The following is a description of a gene set: species: Homo sapiens Activation of innate immune receptors including Toll-like receptors (TLRs) by pathogen-associated molecular patterns (PAMPs) is crucial in the host defense against microbial infections. On the other hand, these receptors are also activated by diverse molecules of host-cell origin. These molecules are known as damage-associated molecular patterns (DAMPs). <p>DAMPs are released from necrotic cells or secreted from activated cells in response to tissue damage to mediate tissue repair by promoting inflammatory responses. However, DAMPs have also been implicated in the pathogenesis of many inflammatory and autoimmune diseases, including rheumatoid arthritis (RA), systemic lupus erythematosus (SLE), and atherosclerosis (Duffy L & O’Reilly SC 2016; Fukuda D et al., 2019; Gong T et al., 2020; Liu J et al., 2022). There is a correlation between high level of endogenous TLR ligands and different chronic inflammatory conditions in human subjects and mouse models (Duvvuri B & Lood C et al., 2019; Negishi H et al., 2019; Punnanitinont A et al., 2022). The mechanism underlying the switch from DAMPs that initiate controlled tissue repair, to those that mediate chronic, uncontrolled inflammation is still unclear. Studies suggest that an abnormal increase in protein citrullination is involved in disease pathophysiology (Anzilotti C et al., 2010; Sanchez-Pernaute O et al., 2013; Sokolove J et al., 2011; Sharma P et al., 2012; Olsen I et al., 2018). Moreover, gene polymorphisms within TLRs may predispose to the abnormal inflammatory responses associated with chronic diseases including autoimmune diseases (Devarapu SK & Anders HJ 2018; Zhang Y et al., 2021). For example, polymorphisms that increase expression of TLR7 are associated with a higher risk of SLE. Further, inherited genetic variations can promote autoimmune responses. For example, TLR7 Y264H was identified as a gain-of-function mutation in a patient with SLE (Brown GJ et al., 2022). TLR7 Y264H exhibited enhanced affinity to endogenous guanosine-containing ligands (Brown GJ et al., 2022). Reactome Pathway: Defective regulation of TLR7 by endogenous ligand part of: Diseases associated with the TLR signaling cascade, and this is the list of marker genes: TLR7